The following is a description of a gene set: Human Gene Set: HP_CHORIOCAPILLARIS_ATROPHY species: Homo sapiens Atrophy of the capillary lamina of choroid. Choriocapillaris atrophy, and this is the list of marker genes: GUCY2D, CDH3, ACVRL1, PRPH2, CRB1, CYP4V2, TIMP3 (NCBI Gene Id 7078), GUCA1A